Given this list of marker genes Oasl2, Pnp, Trim30a, Lgals9, Irf7, Ifit3, Ccl12, Bst2, Ifi211, Samhd1 (SAM domain and HD domain, 1), Ifih1, Parp14, Parp12, Ccl2, Slfn5, Dhx58, Sp100, Ifitm3, Ifit2, Ifi44, Isg15, Stat1, Mndal (myeloid nuclear differentiation antigen like), Ifi204, Slfn8, Serpina3g, Ifi209, Ifi203, Zbp1 (NCBI Gene Id 80562), Rsad2, Ifi47, Igtp, Cxcl10, Fcgr1, here is a description of the gene set: Cytokines mediate cell-cell communication in the immune system and represent important therapeutic targets. A myriad of studies have highlighted their central role in immune function, yet we lack a global view of the cellular responses of each immune cell type to each cytokine. To address this gap, the authors created the Immune Dictionary, a compendium of single-cell transcriptomic profiles of more than 17 immune cell types in response to each of 86 cytokines (>1,400 cytokine-cell type combinations) in mouse lymph nodes in vivo. A cytokine-centric view of the dictionary revealed that most cytokines induce highly cell-type-specific responses. For example, the inflammatory cytokine interleukin-1β induces distinct gene programmes in almost every cell type. A cell-type-centric view of the dictionary identified more than 66 cytokine-driven cellular polarization states across immune cell types, including previously uncharacterized states such as an interleukin-18-induced polyfunctional natural killer cell state. from publication Cui A, Huang T, Li S, Ma A, Pérez JL, Sander C, Keskin DB, Wu CJ, Fraenkel E, Hacohen N (PMID 38057668) species: Mus musculus Mouse Gene Set: CUI_MACROPHAGE_IFNE_RESPONSE_UP Genes positively differentially expressed in cell type: Macrophage upon treatment with cytokine: IFN-ε in mouse lymph nodes in vivo.